The following is a description of a gene set: studied in species Mus musculus Mouse Gene Set: GOBP_PURINE_DEOXYRIBONUCLEOSIDE_METABOLIC_PROCESS The chemical reactions and pathways involving any one of a family of organic molecules consisting of a purine base covalently bonded to a sugar deoxyribose (a deoxyribonucleoside)., and this is the list of marker genes: Pnp, Dguok, Gda, Urad, Ada, Urah, Uox, Xdh